The following is a description of a gene set: Human Gene Set: LIANG_SILENCED_BY_METHYLATION_2 from publication Liang G, Gonzales FA, Jones PA, Orntoft TF, Thykjaer T (PMID 11861364) Genes up-regulated in T24 cells (bladder carcinoma) after treatment with decitabine (5-aza-2'-deoxycytidine). species: Homo sapiens Hypermethylation of the promoters of cancer-related genes is often associated with their inactivation during tumorigenesis. Several preclinical and clinical trials have been developed to use DNA methylation inhibitors, such as 5-aza-2'-deoxycytidine (5-Aza-CdR) in attempts to reactivate silenced genes in human cancers. We used high-density oligonucleotide gene expression microarrays to examine the effects of 5-Aza-CdR treatment on human fibroblast cells (LD419) and a human bladder tumor cell line (T24). Data obtained 8 days after recovery from 5-Aza-CdR treatment showed that more genes were induced in tumorigenic cells (genes induced; >or=4-fold) than nontumorigenic cells (genes induced; >or= 4-fold). Approximately 60% of induced genes did not have CpG islands within their 5' regions, suggesting that some genes activated by 5-Aza-CdR may not result from the direct inhibition of promoter methylation. Interestingly, a high percentage of genes activated in both cell types belonged to the IFN signaling pathway, confirming data from other tumor cell types., and this is the list of marker genes: C1S, NT5E, HBEGF, TNFAIP3, MAGEA2, H2AC18, CXCL5 (NCBI Gene Id 6374), SOD2, IFI6, STAT1, LCN2, MAGEA3, SSX2, S100A4, DHRS2, STC1, CTAG1B, H2BC6, IFIT2, MAGEA4, PI3, CCL5 (C-C motif chemokine ligand 5), GAGE1, MX2, MMP1, SAA1, OAS2, H2AC6, IFI44L, CXCL2, IL6, MX1, H19, INHBA, IRF7, ICAM1, SP100, XAF1, MAGEA12, BIK, IFIT3, THBD, STX3, CCL20, IFI44, CXCL6 (NCBI Gene Id 6372), KRT17 (NCBI Gene Id 5103), CSF2, IL13RA2, OAS1, AREG, TNFSF10, UCHL1, C3, SLPI, SERPINB2 (NCBI Gene Id 5055), IFIT1, PTGS2